The following is a description of a gene set: Lacrimation abnormality Abnormality of tear production. Human Gene Set: HP_LACRIMATION_ABNORMALITY species: Homo sapiens, and this is the list of marker genes: BAZ1B, OVOL2, SIX1, NDP, MADD, NHP2, CYP1B1, ERCC6, KRT12, ATOH7, MAFB, METTL27, PRNP, KRT3, GTF2IRD2, MAPT, MRAP, FOXL2, ELP1, SOX10, SREBF1, TBL2, RFC2, MYOC, TEK, CHD7, AP1B1, ERCC8, DKC1, DST (dystonin), ALX4, SLC12A2, VPS37D, SEMA4A, PAX3, PARN, GTF2IRD1, VSX1, LRP1, SCN9A, GTF2I, PTPN22, SEMA3E, LIFR, EYA1, OCRL, NCF1, PIGQ (phosphatidylinositol glycan anchor biosynthesis class Q), TRAPPC11, TINF2, CLDN10, NGLY1, SDHD, ZFHX2, PAX1, SALL4, SLC39A14, FGFR2, GNAQ, CHN1, TP63, STX1A, FZD4, LIMK1, DNAJC30, ELN, LTBP2, TYMS, COL17A1, TACSTD2, AAAS, BUD23, FKBP6, TMEM270, NOP10, NLRP3, UBR1, ZEB1, COL8A2, TWIST2, HLA-DRB1, CLIP2, FGF10, ERCC4, GRHL2, SETBP1, GMPPA, SIX5, FAS, EIF4H, IGSF3, FGFR3, PRDM12